Given this list of marker genes KDM5D, JMJD1C, KDM3B, JMJD6, KDM2A, ALKBH4, PHF8, KDM1B, KDM3A, KDM5B, KDM4C, KDM6A, KDM4D, PHF2, KDM4E, KDM5C, RIOX1, KDM8, UTY, RIOX2, RSBN1, KDM4B, KDM6B, FBXL19, JARID2, KDM1A, KDM4F, KDM7A, KDM4A, KDM2B, KDM5A, HR, here is a description of the gene set: species: Homo sapiens Catalysis of the removal of a methyl group from a protein. Human Gene Set: GOMF_PROTEIN_DEMETHYLASE_ACTIVITY